Given this list of marker genes ABCD1, PDK2, MIR182, ADIPOQ, MIR204, MIR132, SLC45A3, KLHL25, ETFBKMT, NCOR1, MIR33A, ANGPTL4, APOC2, GDF15, TRIB3, SLC22A13, APPL2, PRKAG2, PGK1, ABCD2, PDK1, UGT1A7, PPARG, UGT1A4, IL1B, CPT1A, IRS2, PLA2G3 (NCBI Gene Id 50487), BCKDK (branched chain keto acid dehydrogenase kinase), EIF6, INSIG1, PDK3, IRS1, UBR4, ABCB11, UGT1A8, MIR30C1, TYSND1, UGT1A1, APOA4, DGAT2, APOA5, ACADVL, LONP2, TPK1, FMO4, APOC3, PIBF1, GIP, PANK2, SIRT2, INS, SNCA, NFE2L1, PPARA, AKT1, TWIST1, UGT1A6, SIRT4, SCAP, DCAF5, TREX1 (NCBI Gene Id 82474), UGT1A9, MFSD2A, MIR342, AVP, INSIG2, WDTC1, CAV1, NR1H2, UGT1A10 (UDP glucuronosyltransferase family 1 member A10), MIR548P, ERFE, ERLIN1, PDK4, SREBF1, PPARGC1A, FABP3, SOX9, FMO1, FABP5, KAT2B, ELOVL5, MID1IP1, AVPR1A, PTGS2, BRCA1, GHSR, MLXIPL, PLIN5, CEACAM1, MIR96, PLAA, NR1H3, PPARD, CD74, CYP7A1, APOC1, AKT2, MLYCD, GPIHBP1, SIRT1, LPGAT1, ERLIN2, ACADL, UGT1A3, MIR185, ACACB (acetyl-CoA carboxylase beta), FMO2, MIR766, MTLN, here is a description of the gene set: studied in species Homo sapiens Any process that modulates the frequency, rate or extent of the chemical reactions and pathways involving fatty acids. Human Gene Set: GOBP_REGULATION_OF_FATTY_ACID_METABOLIC_PROCESS